The following is a description of a gene set: species: Mus musculus Mouse Gene Set: MARSON_BOUND_BY_FOXP3_UNSTIMULATED Foxp3+CD4+CD25+ regulatory T (T(reg)) cells are essential for the prevention of autoimmunity. T(reg) cells have an attenuated cytokine response to T-cell receptor stimulation, and can suppress the proliferation and effector function of neighbouring T cells. The forkhead transcription factor Foxp3 (forkhead box P3) is selectively expressed in T(reg) cells, is required for T(reg) development and function, and is sufficient to induce a T(reg) phenotype in conventional CD4+CD25- T cells. Mutations in Foxp3 cause severe, multi-organ autoimmunity in both human and mouse. FOXP3 can cooperate in a DNA-binding complex with NFAT (nuclear factor of activated T cells) to regulate the transcription of several known target genes. However, the global set of genes regulated directly by Foxp3 is not known and consequently, how this transcription factor controls the gene expression programme for T(reg) function is not understood. Here we identify Foxp3 target genes and report that many of these are key modulators of T-cell activation and function. Remarkably, the predominant, although not exclusive, effect of Foxp3 occupancy is to suppress the activation of target genes on T-cell stimulation. Foxp3 suppression of its targets appears to be crucial for the normal function of T(reg) cells, because overactive variants of some target genes are known to be associated with autoimmune disease. Genes with promoters bound by FOXP3 in unstimulated hybridoma cells. from publication Marson A, Kretschmer K, Frampton GM, Jacobsen ES, Polansky JK, MacIsaac KD, Levine SS, Fraenkel E, von Boehmer H, Young RA (PMID 17237765), and this is the list of marker genes: Fkbp1b, Slc25a37, Cdc27, Dipk1a, Stat6, Rnf128, Vezf1, Tha1, Emp3 (epithelial membrane protein 3), Actrt3, Jarid2, Msh6, Fgd6, Shisa5, Syf2, Mtg1 (NCBI Gene Id 212508), Vps11, Rspry1, Adora2a, Egr2, Kdm6a, Wdpcp, Numa1, Stat3, Cenpm, Pxmp4, Ufc1, Dck, Zfp36l1, Atf5, Gng2, Ptgr3, Mob1a (MOB kinase activator 1A), Pik3ip1, Gm5586, Car12, Mrpl45, Atp5mg, Pabpc1 (NCBI Gene Id 18458), Mfsd11, Acat1, Pcbp1, Cr1l, Slc9a9, Tshz1, Cdk5rap3, Arsb, Ppwd1, Ubl3, Klrb1c, Tmem222, Gpd2, Sirt1, Mbp, Serpinb7, 1700056E22Rik, Lrrc66, Tprg1l, Ets1, Mto1, Rbks, Cd53, Pkn3, Rundc3b, Ccpg1, Ddx24, St8sia4, Cysltr1, Imp3, Cdc40, Rgs2, Atp6v0a1, Tmem30a, Atosa, A130010J15Rik, Cenpl, F2rl2, Fbxw10, Mbnl1, Dusp10, Ubb (NCBI Gene Id 22187), Tcf4, Slc25a45, Kctd2, Tmem71, Tat, Mindy2, Igsf8 (NCBI Gene Id 98593), Knl1, Cnpy2, Cpt1a, Ccn2, Npat, Hnrnpul1 (heterogeneous nuclear ribonucleoprotein U-like 1), Gm5630, Fbrs, Mob3a, Naa15, Usp21, Ly96, Enoph1, Supt7l, Mrps31, Gpr171, Syne3, Iba57, Trappc1, Tapt1, Lrrc8d, Herc3, Tgfb1 (transforming growth factor, beta 1), Slc39a3, Fyn, Ube2v1, Iscu, Tom1l2, Plekhg6, Ccnd2, Mlec, Yes1, Mynn, Prr15l, Ubb-ps, Dclre1c, Usp3, Slc2a8, Rbm5, Arhgef12, 4930412M03Rik, Mib1, Tomm34, H3f3a, Irf4, Dnajb6, Nfatc3, Kiss1r, St6galnac1, Sacm1l, Kdm5a, Lrrc75b, Prune1, Ccdc38 (NCBI Gene Id 237465), Nr1d1, Cenpk, Sema4a, Prrg4 (proline rich Gla (G-carboxyglutamic acid) 4 (transmembrane)), Plppr3, Ggnbp2, Ttll6, Mapk6, Csk, Gins1, Fntb, Rps26, Osbpl8, Egln1, Mcm3, Gpx2, Abt1, Polr3b, Kif11, H3c3, H2aj, Sumo2, Abhd12, Csnk1g2, Spty2d1, Nup62, Amdhd1, Ndor1, Slc20a1, Zfp280b, Dennd6a, Gm5527, Tubb4b, H4c4, Dhx38, Exosc4, Nfkb1, Cmtm6, H4c6, Gm5561, Pde12, Stx7, Lrrc10, Setdb1, Tgfbr2, Ncor1, Trpv2, Psmc1, Trdmt1, Wee1, Gars1, Efcab9, Gcnt3, Pitpnb, Ddb1, Ptk2, Ube2d3, Bspry, Ddx42, Psma3, Smyd3, Or10s1, Las1l, Clcc1, Lrrc41, Ubxn8, Stoml1, Ercc3, Jund, Khnyn, Eapp, Wdr20, Fyb1, Cops7b, H2bc13, Mettl27, Brms1l, Cgrrf1, Ascc1, Asf1a, Aldh3a2, Praf2, Dap, Haus6, Ube3b, Vsig8, Mat2b, Isy1 (ISY1 splicing factor homolog), Ric1, Oplah, Fbxl3, Zfp1, Or6c66, Sgpp1, Cd28, Npb, H3f4, 4930542C12Rik, Kcnn4, Hadha, Cryba4, Srp19, Surf4, Rheb, Armc8, H2bc18, Atp2a1, Zpbp2, Xbp1, Nasp, Cox20, Cbln3, Papln, Dnase1l1, Tmem62, Pik3cg, Wasf2, Rps6ka5, Ubr1, Tnfsf4, Ifi203, Nfe2l2, Ndufc1, Chordc1, Ptpn2, Nqo2, Retreg2, Ndufb3, Wac, Cpne7, Slc25a24, Mrpl48, H2ac25, Tbc1d10b, Lgals8, Meig1, Gimap6, Txnip, Vsir, Il10ra, Dbr1, Hnrnpu, Limd2, Cat, Slfn5, Ccr8 (C-C motif chemokine receptor 8), Clec12a, Utp23, Alg9, Rtn4ip1, Ifi27, Xpa, Cnot2, Lyset, Prpf40a, Gtf2a2 (NCBI Gene Id 83601), Nat9, Tax1bp1, Ranbp2, H2ac18, Dntt, Atp1a2, Trappc2b, Herc1, Tmem60, Itgb3bp, Fbxo46, Aurkb, Tjp1, Setd5, Saraf, Traf3ip2, Dync2i2, Gm55896, H2ac24, Tnfrsf18, Fbl, H2bc22, Zmpste24, Retreg3, Tfb2m, Tmem147, Ccdc18, Kdm2b, Polr2a, Usp4, Fyco1, Babam2, Stx1a, Cstpp1, Gabarap, Tnfrsf1b, Tmem134, Cish, Dbf4, Gtf2b, Ogt, Tle3, Ndufs4, Cdkn1b, Zfp275, H3c10 (H3 clustered histone 10), Glt8d2, Det1, Psmd8, Kpnb1, Ctdsp1, Slu7, Arhgap1, Frat2, Rhbdd3, Pgam1, Slc23a3, Nsun4, Cltc (NCBI Gene Id 97762), Or9r7, Dnai4, Cwf19l2, H2bc8, Arid3b (NCBI Gene Id 56380), Tor4a, Plekhs1, H2ac12, Trim12c, Kif18b, Wdr45 (NCBI Gene Id 97597), Pcnx3, Smad3, Gen1, Gm5242, Elavl1, Pik3cd, Arf6, Shmt2, Ptgir, H4c3, Arid5b, Dph6, Cd48, B9d2, Gimap1, Eid1, Ripk1, Wdr44, Or9r3, Abca7, Arl4a, Pms2, Uqcrh, Lrr1 (leucine rich repeat protein 1), Zbtb25, H4c9, Srgn, Ell, Sytl1, Atm, Ramp1, Ly6a, Itgal, Cd226, Degs2, Slc35d1, Tbl1x, Tcta, H2ac22, Armc6, Arhgap11a, Abcb6, Amz2 (NCBI Gene Id 13929), D430018E03Rik, Actr2, Tkfc, Dmpk, Trim16, Gpr18, Mov10, Arid1a, Elp3, Garin2, Dohh, Poln, Gm5420, Sf1, Ctse, Plekhf1, H2ac11, Cenpa, Uri1, Zranb3, Nt5e, Mrps33, Mphosph8, Elane, Anxa9, Trappc2, Ttk, Pkn2, Rad52, Rmnd5b, Smad7, Copg1, H3c7, Kif5b, Tnfrsf26, Fgd3, Aimp2, Ift46, Cd3d, H2bc14, Xpo7, Ap4b1 (adaptor-related protein complex AP-4, beta 1), Smap2, Pttg1, Hibadh, Il9, Fli1, Aplp2, Dmwd, Sec14l1 (SEC14-like lipid binding 1), Lamtor1, Stk11ip, Slc26a11, Cytip, Gfpt1, Evi2b, Il17ra, Ago2, Npc1, Ostf1, Stk4, Zfp280d, Gpr146, Sephs2, Ccni, Dusp6, Map3k20, Ern1, Sec11a, P2ry10b, Poldip2, Cdc123, Gm5473, Kat6b, Tprn, Vps45, Tsc22d4, Gtf3c6, H3f3b, Camk2d, Prps1, Arhgap12, Ube2h, Ankmy2, 1700055D18Rik, Gm1818 (predicted gene 1818), Abhd2, Nf2, Evi2a, Gbp2, Tafazzin, Msgn1, Zfp879, Vezt, Psen1, Ms4a6c, Nabp1, Ppp4c, Rad1, Edaradd (EDAR associated via death domain), Gmds, Mier1, Psmd4, Aqp11, Slx9, Aox1, Tra2a (transformer 2 alpha), Stx16, Slc35b4, Tesk2, Creb3l4, Adh1, Map4k4, Traip, Sik3, Jaml, Mr1, Cnppd1, Nudcd2, Nkap, Crebl2, Thyn1, Gm5917, Rnasek, H3c11, B4galt1, Zer1 (NCBI Gene Id 227693), Eps15, Slc22a4, Ddias, H2ac4, Fam117a, Mgme1, Laptm5, Anapc16, Acbd5, Dnmbp, Fam149b, Mfsd4b5, Riok1, Ndfip1, Pnkp, Chek1, P2ry10, Afg2b, Ldlrap1, Mdm4 (transformed mouse 3T3 cell double minute 4), Gm5388, Sgsh, Cfap43, Atp10d, Gm10257, Sub1, H2bc12, Themis, Pym1 (PYM homolog 1, exon junction complex associated factor), Cd3e, Fosb, H3c14, A930024E05Rik, Dennd1b, Pygl, Nuf2, Nmi, Trp53, Dclre1b (NCBI Gene Id 99645), Eif3h, Klf6, Stk10, Dut, Fars2, Metrnl (meteorin, glial cell differentiation regulator-like), Lpcat3, Mllt3, H2bc11, Pde7b, Usf1, Dcaf1, Sertad3, Creb3l3, Stkld1 (NCBI Gene Id 279029), Gm5617 (predicted gene 5617), Cpsf2, Frmd8, Zap70, Tnfrsf19, Nif3l1, Btnl10, Rtf2, Cep57l1, Ggt1, Ncoa3 (nuclear receptor coactivator 3), H4c2, Fosl2, Rbm47, Eea1, Panx1, Vtcn1, 4921524J17Rik, Cage1, Eloa, Stc2 (NCBI Gene Id 20857), Actr3, Mpp2, Xrcc4, Icam2, Nyap1, Trp53inp1, Zfand6, Cdk9, H3c2 (H3 clustered histone 2), Wdr26, Zbed5, Srsf1, Emp1, Cab39, Slc6a4, Ech1, Wdcp, Kif15, Mthfd2, Mink1, BC049715, Gimap4, Mfsd6, Tmem59, Akt1s1, Sytl2, Zdhhc9, Gm4973, Ldlrad3, Tuba8, Ifit2 (NCBI Gene Id 15958), Basp1, Rbm6, Scmh1, Rcc2 (regulator of chromosome condensation 2), Ctss, Eola1, Hbp1, Macroh2a1, Idh1, Qpctl, Arhgap15, Cdk17, Dnajb12, Fzd7, A930012O16Rik, Ppil3, Wdr31, Elovl5, Tmem167, Lpxn, Zfp146, Irag2, Shc1, Ppp5c, Ssna1, Slc25a15, Tmed5, Eif4e3, Tubg1, Hmgb1, Leprotl1, Dars2, Cdkn2d, Glipr1, Bbs4, Slc30a7, Rwdd1, Tor1aip2, Fzr1, Mettl5, Arhgap45, Ubap2l, Kcna3, Me1, Itgav, Blm, Tec, Fgl2, Eef2, Brix1, Dmac1, Nsmce1, Gna13, Mrpl33, Hadhb, Pot1a, Slc16a6, Cers2, H2ac8, Pou2f3, Zc3hav1, Manba, Urm1, Xpo1, Ubald2, Dlx1, Madd, Rhoa, Mrpl34, Cpd, Tpp2, Sppl2a, Lrrc8c, Stxbp4, Lrrc42, Nptn, H1f4, Lysmd3, Hmg20a, Hnrnpdl, Ankrd13c, Ttc41, Tmed10, H2ac6, Ajuba, Tmc6, Rplp1, Fscn2, Mettl21a, H3c6, Xcl1, Eri2, Ankzf1, Prpf8, Polr1e, Zfp874a, Entpd5, Map4k1, Mylpf, Haus3, Smarcc1, Cxcr6 (C-X-C motif chemokine receptor 6), H4c11, Mindy3, Inpp1, Rbl1, Or6c66b, Fdxacb1, Tes, Itga9, Orc5, Wbp1, Phf23, Med16 (NCBI Gene Id 216154), Or2y8, Abhd8, Serpina11, Sugct, Add1, Hspa4, Ylpm1, Slc22a5, Tbc1d15, Rbpj, Naa16, Apex2, Dnajc1, Kri1, Siae, Hp1bp3, Prcc, Naif1, Coq8a, Cntf, Txn1, Slc4a1ap, Elk4, Acad8, Tcp11l2, Slc17a6 (NCBI Gene Id 73055), Aqp9 (NCBI Gene Id 72262), Irf8, Pon2, Psd4, Wbp11, Kcnab3, Spata6, Bzw2, Atp6v1d, Dhx33, Rps29, Tsc22d3, Hivep1, H3c4, Dda1, Hsp90b1, Mical1 (NCBI Gene Id 171580), Flad1 (NCBI Gene Id 319945), Cnot6l, Eif1, Map3k1, Srpk2, Spag6, Tbc1d17, Acsl4, Prtn3, Ccdc28a, Dars1, Smg9, Pdk1, Peak1, Arl6ip6, Pou3f3, Mplkip, Ncapd3, Utp6, Mok, Paqr7, Cdk19, Arid5a, Herc4 (hect domain and RLD 4), Mapkapk3, Pikfyve, Gdi2, Hnrnpl, Pole4, Angel2, Ewsr1, Pias4, Cpa3, Ptpn22, Csnk1a1, Vamp4, Rab18, H3c1, Fam185a, Pcmt1, Kcnj2, Pigk, Itm2b, Mdh1, Rasgrp4, Hpgds, Myo1e (NCBI Gene Id 71602), Tnfrsf9, Dapk3, Sertad1 (NCBI Gene Id 66188), Scml4, Pdcd1, Wnt2b, Zfp958, Ccdc47, Nup35, Septin6, Mef2a, Bltp2, Mbtps2, Ankrd22, Prmt5, Mbd4, Tmem199, Arpp21, Ccng2, AA467197, Ak2 (adenylate kinase 2), Tmem167b, Rhbdf1, Hnrnpf, Ing3, Nup43, Drc3, H2ac13, Zwint, Psmb11, H3c13 (NCBI Gene Id 319154), Hycc2, Rgs14, Usp6nl, Snx31 (NCBI Gene Id 66696), E230015B07Rik, Tmc8, Anxa7, Rgs1, Eif5, Rpl27a-ps4, Jak2, Kif23, Rhob, Morc2a (NCBI Gene Id 74522), Strada, Arl6ip5, Creb1, Gja1, Pml, Wrap53 (NCBI Gene Id 216853), Clk1, Sesn1, Plscr2, Vmp1, Arih1, Cenpc1, 1110059G10Rik, Ncapd2, Avpi1, Lztfl1, Fanci, Gata3, Aggf1, Tmpo, Gm5865, Psme3ip1, Itk, Dusp16, Rps3a1, Rab19, Cartpt, Plekhb1, Nedd9, Lysmd1, Aplf, Spaca4, Map2k6, Izumo4, Cd3g (CD3 antigen, gamma polypeptide), Tmem150cos, Jmjd6, Ankrd61, Vps37b, Golph3l, St3gal4, Harbi1, Sart3, Cfap68, Eif2s1, Asb3, Ap4m1, Tmem140 (NCBI Gene Id 68487), Gm14296, Lrrc75a, Ptprc, Myc, Msh3, Nudt4 (nudix hydrolase 4), Pkm, Edem1, Ccdc77, Nipa1 (non imprinted in Prader-Willi/Angelman syndrome 1 homolog (human)), Foxo3, Tpst2, Prdx1, Tex261, Etaa1, Mpg, Eif2ak3, Nxn (NCBI Gene Id 18230), Gm15850, Ddit4, Nmrk1, Ywhaz, Arhgdib, Gpr82, 4932435O22Rik, Pou2af1, Mmp9, H4c12, 4930539J05Rik (NCBI Gene Id 75227), Camk1d, Hmmr, Alyref, Rgs9bp, Amph, Kctd10, Lrp2bp, Tbrg1, Paip2b, Tceanc2, Atg12, Extl2, Mad1l1, Erlec1, Ggps1 (NCBI Gene Id 97873), H3c8, Cited2, Ngly1, Trpc4ap, Lbr, Zbtb5, H2ac10, Ints13, Ppt1, Clec2d, Ppp1r13b (protein phosphatase 1, regulatory subunit 13B), Arl15, Prelid3a (PRELI domain containing 3A), Cstb, H4c8, Rmnd5a, Oacyl (O-acyltransferase like), Tmem203 (NCBI Gene Id 227615), Rnmt, Tmem50a, Arhgef6, H1f6, Ptprj, Rbm7, Fam98b, Tiparp, H4c1, Psmc3, Kdm5b, 4933434E20Rik, Txnl4b, Ube2r2, Oga, Me2, Elf1, Fkbp1a, Plgrkt, Med1, Plxnc1, Prdx6, Ppp2r5c, Nudt5, H2ac19, Rbl2, Arcn1, Gimap5, Atxn1, Ambra1, Marchf6, Rmc1, Ggta1, Lsm5, Itprip, Id2, Hhat, Etv3, Pja1, Mrnip, Cx3cr1, Moxd2, Rps6ka3, Uba3, Efcab2, Pes1, Unc5a, Leo1, Lcp2, Pigl, Stk26, Zkscan14, Pdcd6ip, Rlbp1, Park7, Nemf, Zbtb1, Nfia, Wasf1 (NCBI Gene Id 83767), H1f5, Dnajb4, Elac1, H3c15, Grk6, Podnl1, Sephs1, Tmod3, Eif4ebp2, Dynlt4, Lin28a, Picalm, Atg7, Itch, Hspa9, Golph3, Arl4c, P2ry14, Bloc1s6, Fam13b, Frg1, Erap1, 0610010K14Rik, Nkx2-6, Grm6, Fhip1b, Sash3, Gpaa1, Rnf38, Zpbp, Ppp3ca, Mis18bp1, Mns1, Rdx, Top2b, Actg1, Cgas, Slc37a3, Eif3k, Lif, Nxt2, Scnm1, Ldb1, Mcm7, Poglut3, Znrf2, Tex19.1, Art2b, Cdkl3, Trim8, Pde6d, Vta1, Ly9, Zfp609, Atf7ip, Dgka (NCBI Gene Id 13139), Dok2, Mapre2, 2700097O09Rik, Cabp1, Fth1, Gm5444, H2bc6, Timm22, Map2k2, Prkar1a, Grb2, Sh2d3c, Lman2, Cd274, Smc1a, Akr1c13, Ap2a2 (NCBI Gene Id 97365), Atg13, Ssbp3, Ttc5, Gpr65, Tnpo1, H2bc21, Smpd2, Shroom1, Lrp10, H2bc7, Tpm4, Ythdf3, Arl4d, Ppp1cb, Nrdc, Crygf, Srp54a, Vstm2l, Nhlrc2, Nanp, Mcm10, Rest, Dync2i1, Spa17, Tmigd1, Ms4a6b, Wbp2, Slc17a5 (NCBI Gene Id 76855), H4c18, AI504432, Bcl10, Ccr4, Mtfmt, Slc39a1, Gmfb, Rsrp1, Rgs5, Tmem164, Uba6, E2f2, Mknk1, Gngt2, 5330438D12Rik, Bloc1s5, Ift122, H4c16, Rfx3, Dnaaf11, Mindy1, Or7e174 (olfactory receptor family 7 subfamily E member 174), Fgfr1op2, Fcrla, Npas4, Tpgs2, Cracdl, Sestd1, Arg2, Stap1 (signal transducing adaptor family member 1), Kpna3, Rab2a, Snhg16, Uvrag, Cdk11b, Stx12, Cd84, Kti12, Lsm14a, Junb (jun B proto-oncogene), Insig1, Anapc5, Polg2, Ube2b, Ppp2r5a, Zfand5, Ly6c1, Phf6, Slc25a40, Krr1, Zdhhc17, Tmem91, Arhgap10, Rag1, Kif3a, Syt3, Rpl29, Ect2, Cox11, Rimoc1, H2ac7, Ppp2r2a, Bnip2, Oaf, Usp48, Myl6b, Supv3l1, Sharpin, Fubp1, R3hdm1, Gm4992, Sft2d2, Tent2, Cyp1a1, Kdm5c, Akirin1, Pnpla7, Atp5pd, Phtf2, Os9, Sp6, Psmb5, Otud5, H4c14, Prpsap1, Dhrs3, Orai2 (ORAI calcium release-activated calcium modulator 2), Map3k11, Map3k14, Mtrf1, F12, Dhfr, Cd276, Med24, Fcgr3, Prpf18, Cep120, H2bc15, Epc2, Terf1, Glb1, Snx12, Lsm3, Ribc1 (RIB43A domain with coiled-coils 1), Rdm1, Gm4852, Ifi204, Hsph1, Nme1, Or12j3, Sypl1, Ddb2, Gpr22, Mnt, Nup153, Tor1aip1, Ttc16, Haus4, Lyrm4, Ccny, Helz, Ube2w, Tmem106b, Maf1, Trpa1, Dclre1a, Zeb1 (NCBI Gene Id 73165), Gsr, Zfp105, Or13a19, Mlh1, Zkscan5, Rasa3, Trim33, Cul3